Given this list of marker genes INTS11, SLC25A11, FBXW8, COPS5, VAPB, MYO5A, AK7, PRPF31, DEPTOR, CNOT11, GATAD1, CCR5, FBXO3, SMC1A, PDAP1, CHEK1, RACGAP1, ERG28, KCNK6, KDM4A, PPP2R3C, GPR89B, KLC3, JPT2, CCDC61, GCNT1, DDX11, RBMX, PCNA, TRAF5, TTC9C, RBM14, TEAD1, DHRS3, SNRPN, PSAT1, CLEC14A, CASP1, ARL6IP1, NAA38, DUSP2, MYO1C, ARPC1A, HRAS, ST13, P2RX7, GRHL1 (NCBI Gene Id 29841), YKT6, SCN1A, KIF23 (NCBI Gene Id 981), MED24, TTC33, SERPINE2, SLFN12, RBM4, TTF2, PTPN9, KCTD9, HIF3A, RXRA, POLE, RABGAP1L, RAD21, PASK, RFC1, DZIP3, SF3A1, LANCL2, COG2, MLLT3, HSPD1 (NCBI Gene Id 56733), PSD4, HTRA2, CYP4X1, FADS1, NHLH1, CSNK2A1, AKT2, GK2, EPCIP, VPS9D1, DCUN1D1, INTS4, MMRN2 (multimerin 2), SLC25A40, EXOC6, CD38, SOX4, FAT4, RENBP, NUP50, IDI1, NLRX1, GOSR2, FANCM, SMN1, CORO1C, MEAK7, IPP, OGFRL1, RFC2 (replication factor C subunit 2), PFN1, ATP6V0B, MTIF2, BAG6, CCNG1, PAM, CDC27, DPYSL2, PRIM1, APEX2, BRIP1, GALNT3, TTC1, PSEN1, IPO9, MTMR14, OXA1L, STRAP, SNX9, PEX11A, SPATA2, TMPO, AK2, ZMAT2 (NCBI Gene Id 153527), H2AZ1, PIMREG, TWSG1 (twisted gastrulation BMP signaling modulator 1), DOK1, C11orf87, C16orf74, IL2RB (NCBI Gene Id 3602), MED10, MATCAP2, DHFR, SCAMP2 (secretory carrier membrane protein 2), MDM1, ILDR1, GALNT1, RMND5B, GOT2, LONP2 (lon peptidase 2, peroxisomal), CAPG, PFAS, NR4A2, PLEKHG2, TNS1, BLVRA, PTS, STRN, RNF19A, THAP1, EEPD1, RAP1A, SERPINB6, XPO6, ALS2, RPRD1A, PMPCB, PDP2, NELFCD, CYFIP2, VCP, NRP2, KIF20B, SLC39A4, ITGAL, FARP1, FOXD2, TM6SF1, CD81, FANCD2, CSNK1A1, CAPN1, E2F1, ATP6V1H, TRAIP, MLKL, SUV39H1, ALCAM, LAG3, PTAR1, RCHY1, PSMB7, GTF2H2, GCAT, AARSD1, FAM72A, PDCD1LG2, PHKA2, MANBA, OSBPL3, RBBP8, PSMB9, SIK2, PDSS1, NDC80, PPP2R1A, PPIP5K1, DPP3, here is a description of the gene set: STAT3, an essential transcription factor with pleiotropic functions, plays critical roles in the pathogenesis of autoimmunity. Despite recent data linking STAT3 with inflammatory bowel disease, exactly how it contributes to chronic intestinal inflammation is not known. Using a T cell transfer model of colitis we found that STAT3 expression in T cells was essential for the induction of both colitis and systemic inflammation. STAT3 was critical in modulating the balance of T helper 17 (Th17) and regulatory T (Treg) cells, as well as in promoting CD4+ T cell proliferation. We used chromatin immunoprecipitation and massive parallel sequencing (ChIP-Seq) to define the genome-wide targets of STAT3 in CD4+ T cells. We found that STAT3 bound to multiple genes involved in Th17 cell differentiation, cell activation, proliferation and survival, regulating both expression and epigenetic modifications. Thus, STAT3 orchestrates multiple critical aspects of T cell function in inflammation and homeostasis. Human Gene Set: GSE21670_TGFB_VS_TGFB_AND_IL6_TREATED_STAT3_KO_CD4_TCELL_DN from publication Durant L, Watford WT, Ramos HL, Laurence A, Vahedi G, Wei L, Takahashi H, Sun HW, Kanno Y, Powrie F, O'Shea JJ (PMID 20493732) Genes down-regulated in CD4 T cells with STAT3 knockout: TGF beta versus TGF beta and IL6. studied in species Homo sapiens